Given this list of marker genes DDX19B, NCAPH2, TPM1 (tropomyosin 1), TSR2, ITGA4, MRC2, CLIP2, ATP2B1, GNGT1, MGST3 (NCBI Gene Id 9272), IL13RA2, SMARCD1, PDE8B, CRY2, TAF13, ATP1B1, KCTD17, REXO5, LRBA, NAT2, GTF2E1, EHHADH, SRI, ZFHX3, ERI2, MYL5, HLF, PPP1R12B, SAMM50, F9, DDX11, PNP, AVPR2, STK38, OCLN, CCL5, MITF, SUSD6, RERE (arginine-glutamic acid dipeptide repeats), ANAPC15, ODC1, OSBPL3, NCF2, DSC3, IL1RN, MKNK2, RPS6KA4, SERPINB6, H2BC21, GARRE1, LIPF, ZNF423, GRIK2, IKBKG, OPRK1, SSNA1, MEGF9, SRCAP (Snf2 related CREBBP activator protein), IRF6, CLUL1, RGS16, ITGAE, CSRNP2, GAB1, VNN1, CD3D (CD3 delta subunit of T-cell receptor complex), STMN1, IGSF6, KCNA5, MICAL3, PRM1, KIF3B, SPINT2, FLT1, SACS, NBEAL2, PLOD2, ARF3, TMEM109, NT5E, COL4A4 (NCBI Gene Id 1286), CAPG, HLA-DOB, DDB2, RALB, THY1, DPF1, LITAF, RDX, COL15A1, PNLIP, ABCG1 (NCBI Gene Id 9619), MRPL49, NEDD8, DIXDC1, HHEX, CLIP3, CRADD, GSN, ANGPT1, ACSL3, AHNAK, RORB, COL16A1, FMO3, IFNA6, SLC26A3, USP6NL, SYCP1, SERPINB10, SLC4A7, ROM1, RUBCN, G6PC1, CALD1, HCG4, BTBD8, TRIAP1, ZNF133, CHD3, MYO9B, VAMP8, ADAR, PDGFB, MEP1A (NCBI Gene Id 4224), CCR4, CCL22, MAGEB3, EFNB1, STX8, FLNA, SEPTIN2, MRAS (NCBI Gene Id 654181), PRELID3A, KIAA0087, TUBB, C4BPA, EXT2, STXBP1, KCND2, TUBB4A, EFS, BASP1, CD101, M6PR (mannose-6-phosphate receptor, cation dependent), AMELY, CRX (cone-rod homeobox), EPHB3, CADPS, GM2A, BTN2A1, TYMP, SLC25A11, NCF4, SLC19A2, TJP3, APOBEC3C, CEACAM4 (CEA cell adhesion molecule 4), MYL6, BAAT, LHCGR, KRT33A, IRF3, PPP2R5D, H2AC6, DEDD, MGA, DIDO1, SF3B4, FCGR2B, LMNA, PDS5B, HOXB1, LCN1, PITPNB, DYRK3, PACS2, METTL1, EPOR, TLL1, KDSR, PIP4K2A, AURKC, DAZL, MLF1, JADE3, RABL3, KDELR2, PCYT1B, KLRG1, ARSL, CAMP, PRICKLE3, LGALS9, AP2B1, AGER, NOP2, here is a description of the gene set: from publication Anandasabapathy N, Victora GD, Meredith M, Feder R, Dong B, Kluger C, Yao K, Dustin ML, Nussenzweig MC, Steinman RM, Liu K (PMID 21788405) Genes up-regulated in spleen CD8+ dendritic cells versus bone marrow monocytes. To understand the functional relationship between brain dendritic cells (brain DCs) and other myeloid cells, we compared the gene expression profile of m/chDCs to that of bone marrow monocytes, brain microglia and classical spleen CD8+ and CD8- DCs. In order to obtain enough brain DCs for mRNA extraction, we expanded brain DCs with in vivo Flt3L treatment before purification. studied in species Homo sapiens Human Gene Set: GSE29949_CD8_POS_DC_SPLEEN_VS_MONOCYTE_BONE_MARROW_UP